Given this list of marker genes Fshr, Slc5a7, Pebp1, Chat, Ache, Bche, Slc44a4, here is a description of the gene set: species: Mus musculus The chemical reactions and pathways involving an acetate ester, any carboxylic ester where the carboxylic acid component is acetic acid. Mouse Gene Set: GOBP_ACETATE_ESTER_METABOLIC_PROCESS